Given this list of marker genes MSH6, MSH2, PMS2, TGFBR2, PIK3CA, RSPO1, PMS1, MLH1, KRAS, EPCAM (epithelial cell adhesion molecule), here is a description of the gene set: A carcinoma of the larynx. Laryngeal carcinoma species: Homo sapiens Human Gene Set: HP_LARYNGEAL_CARCINOMA